The following is a description of a gene set: Genes predicted to be targets of miRBase v22 microRNA hsa-miR-3616-3p in miRDB v6.0 with MirTarget v4 prediction scores > 80 (high confidence targets). from publication Chen Y, Wang X (PMID 31504780) species: Homo sapiens Human Gene Set: MIR3616_3P, and this is the list of marker genes: MLLT11, LUZP1, YPEL1, TBX3, FOXN3, CPSF7, SHROOM2, MCUR1, SNPH, C15orf61, PRR3, VAMP4, KCNB1, PIANP, SPTAN1, ZSCAN32, KCNJ6, BNIPL, RGS8, MXRA7, PRX, SRRM4, RAB21, CLPB, DLX3, IKZF1, PEG10, ORMDL3, GALNT17, AURKA, OGT, MAOB, RGS7BP, PTEN, KMT5A, COG4, FUT8, OGA, ZSCAN30, MESD, BPTF, SYNPO, S100A10, CCAR2, RGMB, GARIN1A, ARHGAP40, PLS3 (NCBI Gene Id 5358), ZC2HC1C, SSH2 (NCBI Gene Id 85464), PRRC2B, GADD45A, ZBTB26, SHANK1, PTPRF, SORT1, ERGIC1, NRG3, FZD1, DDOST, ESCO1, MEF2C, ZKSCAN4